The following is a description of a gene set: studied in species Homo sapiens Congenital hypothyroidism Human Gene Set: HP_CONGENITAL_HYPOTHYROIDISM A type of hypothyroidism with congenital onset., and this is the list of marker genes: PDE4D, TXNRD2, TRAPPC9, MRAP, NKX2-1, YRDC, FOXE1, TPO, ATP6V1B2, KDM6A, THRA, DUOX2, TG, SLC5A5, PAX8, GATA6, IYD, DUOXA2, KMT2D, ADAMTSL1, GLIS3, MC2R, NKX2-5, GNB1, PRKAR1A, B3GLCT, TONSL, NNT, TSHR, STAR, TBC1D24, PLAA